Given this list of marker genes TMBIM6, PINK1, PIK3CB, NOL3, HYOU1, MAP2K1, ENO1 (NCBI Gene Id 81977), here is a description of the gene set: studied in species Homo sapiens Any process that stops, prevents or reduces the frequency, rate or extent of hypoxia-induced intrinsic apoptotic signaling pathway. Human Gene Set: GOBP_NEGATIVE_REGULATION_OF_HYPOXIA_INDUCED_INTRINSIC_APOPTOTIC_SIGNALING_PATHWAY